Given this list of marker genes CD101, DHODH, DPYSL4, AMDHD1, OPLAH, DPYSL3, DPYSL5, DPYSL2, DPEP1, CRMP1, CAD, DCLRE1A, MBLAC2, DCLRE1B, DPYS, here is a description of the gene set: Human Gene Set: GOMF_HYDROLASE_ACTIVITY_ACTING_ON_CARBON_NITROGEN_BUT_NOT_PEPTIDE_BONDS_IN_CYCLIC_AMIDES studied in species Homo sapiens Catalysis of the hydrolysis of any non-peptide carbon-nitrogen bond in a cyclic amide.